The following is a description of a gene set: Array-based comparative genomic hybridization (CGH-array) has a powerful potential for high-throughput identification of genetic aberrations in cell genomes. We identified a homozygous loss of ADAM23 (2q33.3) in the course of a program to screen a panel of gastric cancer (GC) cell lines (1/32, 3.1%) for genomic copy-number aberrations using our custom-made CGH-array. Infrequent homozygous deletion of ADAM23 was also seen in primary gastric tumors (1/39, 2.6%). ADAM23 mRNA was expressed in normal stomach tissue, but not in the majority of GC cell lines without homozygous deletion of this gene. Expression of ADAM23 mRNA was restored to gene-silenced GC cells after treatment with 5-aza 2'-deoxycytidine. The methylation status of the ADAM23 CpG island, which showed promoter activity, correlated inversely with its expression. Methylation of this CpG island was observed both in GC cell lines and in primary GC tissues; in primary tumors with a hypermethylated CpG island, expression of ADAM23 was lower than in adjacent noncancerous tissues. Moreover, restoration of ADAM23 in GC cells reduced their numbers in colony-formation assays. These results suggest that genetic or epigenetic silencing by hypermethylation of the ADAM23 CpG-rich promoter region leads to loss of ADAM23 function, which may be a factor in gastric carcinogenesis. Candidate genes in the regions of copy number loss in gastric cancer cell lines. Human Gene Set: TAKADA_GASTRIC_CANCER_COPY_NUMBER_DN from publication Takada H, Imoto I, Tsuda H, Nakanishi Y, Ichikura T, Mochizuki H, Mitsufuji S, Hosoda F, Hirohashi S, Ohki M, Inazawa J (PMID 16103878) studied in species Homo sapiens, and this is the list of marker genes: FNDC3A, RBFOX1, CYSLTR2, MDH1B, SAXO1, RCBTB2, SMARCA2, ADAMTSL1, SH3GL2, RNASEL, VLDLR, DMRT3, DMRT2, FASTKD2, PUM3, FHIT, CDKN2A, DMRT1, WWOX, CAB39L, RGSL1, KANK1, MTAP, TEK, RB1, RGS16, ADAM23, MDGA2, KCNV2